The following is a description of a gene set: studied in species Homo sapiens Human Gene Set: LBP1_Q6 Genes having at least one occurrence of the motif CAGCTGS in the regions spanning 4 kb centered on their transcription starting sites. This matches the UBP1 transcription factor binding site V$LBP1_Q6 (v7.4 TRANSFAC)., and this is the list of marker genes: DOCK9, PACSIN3, GNB3, AICDA, USF1, NEURL1, CHAT, TNNI2, NHLRC2, CABP1, NOL9, TXNDC12, PCDH9, SGIP1, ZMYM2, MYO7A, RAB5B, USP54, SGCG, ANXA8, GJC2, STXBP6 (NCBI Gene Id 29091), P3H3, TMT1B, ZCCHC24, TRIM46, PICALM, ZNF385A, TNNT2, DPCD, B3GALT2, NEXN-AS1, STIM1, RIN1, FGR, HMGN2 (NCBI Gene Id 94860), RELA, ZNF503, HPCA, DDIT4, DAAM1, YTHDF2, DNHD1, ZRANB1, VAMP3, ARID1A (AT-rich interaction domain 1A), EPHB2, FNDC5, OGFOD2, PKD2L1, AQP5, TNNT3, NTF3, RXRG, EGR2, WBP1L, SYTL2, SUPT16H, BEST3, KMT2A, GFI1, EFNA1, SCN3B, BARX2, GPR37L1, PITX3, MBNL2, TOR1AIP1, GAB2, TMEM25, CHD4, SYTL1, TMEM79, FHL3, DACT1, RNF121, DPP3, NDUFA4L2, CCDC85B, LRFN5, MYPN, MYF5, KRTCAP2, SYT6, AP5M1, LMO4, PHLDB1, FCRLA, MPPED2 (metallophosphoesterase domain containing 2), BSCL2, NBEA, KIF1B, ZMYM4, SLF2, TPCN1, RGR, SMAP2 (NCBI Gene Id 64744), DCLRE1A, BCL7A, SCFD1, MEF2D, BRSK2 (BR serine/threonine kinase 2), ZBTB16, IMMP1L, RUNX3, FCRLB, RCSD1, HMGA2, MYCBP, ACTN3, RNF19B, SSX2IP, KCNIP2 (NCBI Gene Id 30819), INA, BCL9L, HJV, PTGFRN, WNT10B, LCK, ERP27, LINC00303, POLD4, BAZ2A, BRINP3, ELP4, GRK5, GATA3, GRIK3, ATF7IP, CAMK2G, KNCN, MCAM, TRPC4, FITM1, POLL (NCBI Gene Id 27343), ABCB9, ZNF593, DLG2, P2RX4, SHISA4, CNIH2, SELPLG, KCNA2, LZTS2, RGS8, IGFBP6, SOX5, EXOC5, OR2L13, CDC42SE1, TBX3, ART1, BNIP3, VPS45, SKIDA1, PRICKLE1, PPP3CB, TUBA1A, CDKN2C, RORC, KCNQ1DN, PPM1A, XPR1, LOXL4, SLC18A3 (NCBI Gene Id 6572, solute carrier family 18 member A3), ZBTB18, MSS51, SPATA6, HIVEP3, MAN1C1, SMG5, PATL1, LDB3, LINC01138, CSDE1, KCNN3, RPUSD4, TAS1R1, SLITRK5, ACTA1, CELF3, VAMP1, PCF11, CACNB2, SVIL, JMJD1C, NHLH2, PLEKHA6, NOVA1, TRIM8, TMEM109, MYBPH, EIF4G2, IQCD, KLHDC7A, C11orf87, S100A8, MACROD1, CCND2, MLLT11, CRB1 (NCBI Gene Id 6107), TRIT1, HPSE2, PSD, RAPSN (receptor associated protein of the synapse), PPM1J, CDKN1B, ABTB3, F11R, TMOD4, TRIM62, CLIP1, VWA5A, SLC22A17, ZMIZ1, GPR162, SLC26A10P, NXPH4, RASGEF1A, LRRTM3, SPAG6, SH3BGRL3